Given this list of marker genes CCNB1IP1 (cyclin B1 interacting protein 1), MB21D2, PLEKHG4 (NCBI Gene Id 6312), PFN4, SLC18A1, PAH, TEKT1, CXCL6, ZC3H6, KRT25, ADAM28, HES7, FBXW11, CSMD3, KCNAB1, DNAJC5G, CHCT1, GAPDH, COL4A3, ADGRE5, TTC29, PDE6A, KLRC1, SATL1, PRDX1 (NCBI Gene Id 5052), ETNPPL, POU5F2, SLITRK6, CRCT1, TLL1, FJX1, PLSCR4, KCNA5, VASH2 (vasohibin 2), LIPF, SLC26A3, SPP1, AICDA, SLC7A13, GPR39, ODF4, FN3KRP, BAAT, PANX3, SAA2, NLGN3, GRHL3, PTPRU, GRM5, GPR26, SET, JCHAIN, UGT2B4, SNRPN, OLFML1, FGD2, ADRA2B, POU2AF2, KCNIP4, SYCP1, MAP1B, GJC3, SCN10A, GPR173, MUTYH, VSX2, CPNE9, PDE3A, C19orf18, LMOD2, DPM3, BCAR1, B3GNT8, FBXO43, SOX5, SYTL3, BMI1, PROK2, MS4A1, ARSK, SCN8A, PDK4, PCDH15, HJV, CACNA2D3, KCNJ2, PCBD1, NOS1 (nitric oxide synthase 1, NCBI Gene Id 4842), LMNB1, ILDR2 (immunoglobulin like domain containing receptor 2), FCGR3A, TTC23L, LRRC71, SLC25A27, PHOX2A, PIK3R6, GRIA2, TOMM20, CNDP1, SNRNP40, LYZL4, RDX, CLMN, CD177, NWD2, FAM216B (NCBI Gene Id 144809), ASB6, KRTAP8-1, PRCD, CFAP161, PLPPR5, PCSK5, PWWP2B, IRX4, CES4A, COL6A2, FERMT2, COL1A1, HAS1, MYBPH, TOM1L1, MAPK4, FAT2, ETV1, STOX2 (storkhead box 2), CRYGS, TRIM63, SIX3, SYT6, NNMT (nicotinamide N-methyltransferase), KCNMB2, AXDND1, TEX36, IGF2BP2, KCNT2, RGS5, LRRC4, NUDT17, SRPK3, CTXN3, SLC22A3, COL11A1, ARSJ, SLC7A2, IGKC, ELOVL4, CELSR3, IL12A, FGF20, HTR5A, IL1RAPL1, CRYBA1, MYH11, PXT1, MFSD2B, HTR2B, RAB25, SPATA18, FAM81B, KRTAP7-1, GJB3, NEUROD1, C3orf85, RASAL2, CSF3R, CDHR2, SERPINB1, CHRDL1, VCAN, LCE1A, PDP1, HERC4, MEOX2, SNAI1, MDGA2, PRSS46P, SMARCA1, INAVA, BCO1, PIGT, DCST2, MTNR1A (melatonin receptor 1A), PLD4, VNN1, NDP, RPS25, SLC46A2, SMAD6, IQSEC2, GLI3, UNC13C, BICD1, BARD1, MKRN3, CPED1, IGDCC4, MYO3A, USP1, CACYBP, here is a description of the gene set: In order to better understand the factors that regulate B cell differentiation upon exposure to antigen, we compares global gene expression profiles from naive B cells with antigen-specific plasma, germinal center, and memory B cells after immunization with the T-dependent antigen, NP-CGG. The memory B cell-enriched transcripts were then compared with memory T cell-enriched and hematopoietic stem cell-enriched transcripts in order to generate a transcriptional profile of self-renewal within the hematopoietic system. Human Gene Set: GSE4142_PLASMA_CELL_VS_MEMORY_BCELL_UP species: Homo sapiens from publication Luckey CJ, Bhattacharya D, Goldrath AW, Weissman IL, Benoist C, Mathis D (PMID 16492737) Genes up-regulated in plasma cells versus memory B lymphocytes.